Given this list of marker genes SYT11, ANK2, ANKRD63, SLC44A5, RBM25, PEX5, FAM114A2, IGF2BP3, SLC1A2, DNAJC25, BROX (BRO1 domain and CAAX motif containing), WWC2, ETS1, AKR1B10, LHFPL3, TENM1, GEMIN5, HPCAL4, MAP1B, C20orf173, TMEM229A (NCBI Gene Id 730975), CA10 (NCBI Gene Id 769), ONECUT2, GLIPR1L2, RASSF5, RIC8B, CHL1, ADAMTS17, NAP1L2, RC3H1, GABRA4, PABIR2, ANXA1, KCND2, SIAE, ZFP1, CCDC172, FUT9, EIF4A2, CD24, RBFOX2, CERT1 (NCBI Gene Id 10087, ceramide transporter 1), FUT10, COX15 (cytochrome c oxidase assembly homolog COX15), ZNF646, ADI1, ARID2, SLAMF6, MED13L, KPNB1, NDC1 (NDC1 transmembrane nucleoporin), SCN9A, RAB18, RTKN2, RFC3, ZNF148, CLEC3A, PTPRD, UBL3, CCDC15, FAM120A, MTOR, HOXA3, SH3D19, L1CAM, OMD, TM9SF3, CHUK, PLXNC1, UHRF2, GDPD1, CELSR1, FSHB, LGR5, MYOCD, MATCAP2, NCOA3, U2SURP (NCBI Gene Id 23350), SBF2, TANC2, NR2F2, DSEL, LFNG, here is a description of the gene set: studied in species Homo sapiens from publication Chen Y, Wang X (PMID 31504780) Genes predicted to be targets of miRBase v22 microRNA hsa-miR-3192-3p in miRDB v6.0 with MirTarget v4 prediction scores > 80 (high confidence targets). Human Gene Set: MIR3192_3P